Given this list of marker genes CACNA1D, CACNA1F, CACNA1C, PRNP, CACNA1B, CACNA1S, here is a description of the gene set: Scrapie conformation PrPSc to VGCC-Ca2+ -apoptotic pathway. Pathway ID: N01201. Pathway type: Variant. Pathway class: nt06465 Prion disease. studied in species Homo sapiens Pathway Definition from KEGG: PRNP* -| VGCC(N,L-type) -> Ca2+ Human Gene Set: KEGG_MEDICUS_VARIANT_SCRAPIE_CONFORMATION_PRPSC_TO_VGCC_CA2_APOPTOTIC_PATHWAY